Given this list of marker genes RHOA, ARF1, MAPK1, MAPK3, RAB11A, NME1, PLAUR, RAC1, PLD2, PLD1, TIAM1, ARF6, RAB11FIP3, PIP5K1A (phosphatidylinositol-4-phosphate 5-kinase type 1 alpha), KALRN, here is a description of the gene set: from publication Schaefer CF, Anthony K, Krupa S, Buchoff J, Day M, Hannay T, Buetow KH (PMID 18832364) species: Homo sapiens Human Gene Set: PID_ARF6_DOWNSTREAM_PATHWAY Arf6 downstream pathway